Given this list of marker genes LYRM2 (LYR motif containing 2), UBXN7, MAP3K5, AP1M2, IRGQ, EDARADD, RCSD1, SSR3, TMEM104, KLHL9, VAMP7, DESI2, MMADHC, RAP2C, RASL11B, TATDN3, SRP9, UBE2B, SSBP2, DYNLRB1, PTHLH, TMEM128, TACC2, PCBP3, CAPN3, RNF34, SLC25A6, CBX1, RGCC, AFTPH, CNIH4, TRAF2, TOR1AIP2, NBL1, AGAP1, FREM1, RESF1, NAXE, F13A1, MYB, PLCXD2, CDH18, ZC4H2, NCBP3, MYL3, BCLAF1, GREB1L, SEC22B, ATP11C, CDC40, B3GLCT, ADAM10, TLR3, PSPH, SALL2, LZTFL1, LXN, TMEM68, CCR9, CWC15, CD4, MCFD2, CCDC122, ELAPOR1, TAF9B, PTEN, ZNF266, SATB1, FGFR3, MRPS16, NPC1L1, MRAP2, NDUFS2, TUSC2 (tumor suppressor 2, mitochondrial calcium regulator), EPS15, NMB, CPA4, PPM1K (NCBI Gene Id 152926), NDUFV2, STPG1, NRTN, USP43, RFX5, SNN, CAMKK1, KLC4, CCDC28B, TTC9C, TMEM59L, RCAN3, CSTB, OSTM1, HMG20A, RAB3B, GLIS3, DCAF5, H3-5, ARL15, PRKCB, DLK1, TIAM1, FBLN2, RBMX, PLEKHF2, ATP7A, FUOM, SNAI3-AS1, MEF2A, RPS6KB2, FBXL12, SIRT5, PBDC1, FMR1, HARS2, ADAMTS19, MED13L, SLCO6A1, ABI2, MIR22HG, C9orf40, KCTD3, PRNP, MEN1, RTN1, WDSUB1, HEG1, DMKN, DDX42, CMAS, ZBTB33, RPS6KA6, SLC16A10, NTRK1, MAML1, C5orf52, CARNMT1, DENND6A, METTL6, PYCARD, LAGE3, CDC42EP1, CKMT2, CEP57, DOCK6, ABCG2, MLX, CYBRD1 (cytochrome b reductase 1), ETFRF1, INSL6, TRAT1, ITM2B (integral membrane protein 2B), ZNF207, PRIMA1, TBC1D21, CDKN2AIP, WDR45, POLE3, SCARB2, BMPR2, FLJ13224 (NCBI Gene Id 79857), ST8SIA4, CHURC1, AFF4 (ALF transcription elongation factor 4), PKD2, HNRNPA0, LRRC28, SETD4, BEX1, TUG1, ZDHHC17, NXT2, DNAJA1, CEP97, COPS5 (NCBI Gene Id 10987), DHH, CHTOP, MSRB2, CD27, ARMCX3, AP3S1 (adaptor related protein complex 3 subunit sigma 1), RMDN1, HACE1, RALGPS2, KANSL2, CHRNG, TRIM24, NTN1, LDHB, FNBP1L, ELF4, CTH, RABGAP1L, BTF3L4, OLFM2, CPSF6, TP53INP2, KDM5B, MBD5, SDF2, SLC35F1, here is a description of the gene set: studied in species Homo sapiens Genes up-regulated in comparison of CD4 CD8 Int thymocytes versus CD8 thymocytes. T cell development relies on the precise developmental control of various cellular functions for appropriate positive and negative selection. Previously, gene expression profiling of peptide-driven negative selection events in the N15 TCR class I MHC-restricted mouse and D011.10 TCR class II MHC-restricted mouse has offered insights into the coordinate engagement of biological processes affecting thymocyte development. However, there has been little comparable detailed in vivo global genome expression analysis reported for positive selection. We used microarrays to identify the genes differentially expressed during CD8 single positive T cell development in N15 TCR transgenic Rag2 deficient mice. from publication Choi YI, Duke-Cohan JS, Ahmed WB, Handley MA, Mann F, Epstein JA, Clayton LK, Reinherz EL (PMID 19027330) Human Gene Set: GSE13493_CD4INTCD8POS_VS_CD8POS_THYMOCYTE_UP